The following is a description of a gene set: Mouse Gene Set: GOBP_POSITIVE_REGULATION_OF_EPITHELIAL_CELL_MIGRATION Any process that activates or increases the frequency, rate or extent of epithelial cell migration. species: Mus musculus, and this is the list of marker genes: Irs2, Clasp1, Tac1, Capn7, Mtor (mechanistic target of rapamycin kinase), Hbegf, Rreb1, Ccr6, Irs1 (NCBI Gene Id 16367), Iqsec1, Plcg2, Sox9, Rab25, Ppm1f, Vil1, Fgf10, Src, Gab2, Has2, Glipr2, Epb41l4b, Hdac6 (NCBI Gene Id 20374), Arf6 (ADP-ribosylation factor 6), Insl3, Pfn1, Epb41l5, Plcg1, Mapre2, Itga2, Fgf7, Enpp2, Clasp2, Scrib, Arhgap5, Ifng, Hif1a, Tgfb2, Bmpr2, Dock1 (dedicator of cytokinesis 1), Rtn4, Vim, Map4k4, Ctsh, Aqp1, Prkce, Rab11a, Dock5, Tacr1, Serpine1, Mmp9, Hyal1, Adam9, Tgfbr2, Itga3, Ptk2, Jun